The following is a description of a gene set: electronically inferred by orthology from the curated human pathway Reactome Pathway: MyD88 dependent cascade initiated on endosome This event has been computationally inferred from an event that has been demonstrated in another species.<p>The inference is based on the homology mapping from PANTHER. Briefly, reactions for which all involved PhysicalEntities (in input, output and catalyst) have a mapped orthologue/paralogue (for complexes at least 75% of components must have a mapping) are inferred to the other species. species: Mus musculus part of: Toll Like Receptor 7/8 (TLR7/8) Cascade; Toll Like Receptor 9 (TLR9) Cascade, and this is the list of marker genes: Tlr4, Ube2n, Rps27a, Map2k3, Fos, Jun, Mapk7, Ticam2, Nlrc5, Nfkb2, Nfkbib, Tab2, Map3k8, S100b, Ppp2r1b, Map2k4, Ppp2r5d, Ly96, Irak1 (NCBI Gene Id 16179), Mapk14, Cul1, Rela, Peli2, Tab1, Ikbkb, Map2k7, Nfkbia, Lrrc14, Mapk3, Nkiras1, Map2k6, Ubb, Ube2v1, Dusp6, Vrk3, Nfkb1, Ager, Dusp7, Tab3, Casp8 (caspase 8), Cd14, Tifa, Rps6ka5, Ecsit, Nlrx1, Mapk11, Irf7, Hmgb1, Mapk9, Mapk8